Given this list of marker genes STOML1, MPI, RAB13, ATP6V1G2, TLR2, TBC1D22B, RPL19, C5orf34, RBM4, NOSIP, LSG1, PPP2R3C, WDR83OS, TRIQK, DRC3, ZIK1, PRPF31, FAM3A, RTTN, here is a description of the gene set: DNA methylation is essential for normal development and has been implicated in many pathologies including cancer. Our knowledge about the genome-wide distribution of DNA methylation, how it changes during cellular differentiation and how it relates to histone methylation and other chromatin modifications in mammals remains limited. Here we report the generation and analysis of genome-scale DNA methylation profiles at nucleotide resolution in mammalian cells. Using high-throughput reduced representation bisulphite sequencing and single-molecule-based sequencing, we generated DNA methylation maps covering most CpG islands, and a representative sampling of conserved non-coding elements, transposons and other genomic features, for mouse embryonic stem cells, embryonic-stem-cell-derived and primary neural cells, and eight other primary tissues. Several key findings emerge from the data. First, DNA methylation patterns are better correlated with histone methylation patterns than with the underlying genome sequence context. Second, methylation of CpGs are dynamic epigenetic marks that undergo extensive changes during cellular differentiation, particularly in regulatory regions outside of core promoters. Third, analysis of embryonic-stem-cell-derived and primary cells reveals that 'weak' CpG islands associated with a specific set of developmentally regulated genes undergo aberrant hypermethylation during extended proliferation in vitro, in a pattern reminiscent of that reported in some primary tumours. More generally, the results establish reduced representation bisulphite sequencing as a powerful technology for epigenetic profiling of cell populations relevant to developmental biology, cancer and regenerative medicine. from publication Meissner A, Mikkelsen TS, Gu H, Wernig M, Hanna J, Sivachenko A, Zhang X, Bernstein BE, Nusbaum C, Jaffe DB, Gnirke A, Jaenisch R, Lander ES (PMID 18600261) Genes with intermediate-CpG-density promoters (ICP) bearing histone H3 trimethylation mark at K4 (H3K4me3) in neural precursor cells (NPC). Human Gene Set: MEISSNER_NPC_ICP_WITH_H3K4ME3 studied in species Mus musculus